The following is a description of a gene set: Any process that modulates the frequency, rate or extent of ossification, the formation of bone or of a bony substance or the conversion of fibrous tissue or of cartilage into bone or a bony substance. Human Gene Set: GOBP_REGULATION_OF_OSSIFICATION species: Homo sapiens, and this is the list of marker genes: CCR1, ACVR2B, MIR208A, SGMS2, OSR1, STATH, TMEM119, RFLNB, ANKH, GATA1, DDR2, ALOX5, SIX2, ADRB2, SOST, CCN3, BCOR, MDK, TMEM53, SMAD6, BMP7, GDF10, GREM1, ANO6 (anoctamin 6), ATRAID, PTH, WNT10B, TENT5A, BMP4, BMP3, NIPBL, OSR2, ISG15, KREMEN1, WNT5A, MAPK3, SFRP1, CCL3, DHRS3, BMP6, ZMPSTE24, VDR, MAPK14, CYP27B1, WNT4, BGLAP, GFRA4, RFLNA, SLC8A1, DKK1, P3H1, ACTN3, SOX11, INTU, LTBP3, PTN, PTPN11 (protein tyrosine phosphatase non-receptor type 11), TRPM4, TGFB1, CHSY1, RXRB, CSF1, PBX1, TWIST1, NOTUM, SOX9, RUNX2, BCL2, KL, MAPK1, PKDCC, SUV39H1, ACVR2A, NBR1, ENPP1, BMP2K, KREMEN2, SMAD7, TXLNG, SMAD3, FGF23, BMP2, SETD2, ECM1, LTF, ADGRV1, P2RX7, EGR2, ACVR1, SMAD2, ZBTB16, S1PR1, TFAP2A, FBN2, CALCR, HIF1A, COMP, LRP4, SLC20A2, NELL1, MGP, FAM20C, RXRA (retinoid X receptor alpha), OXT, BMPR2, TAC1, FZD9, GPM6B, TACR1, CCN1, PTK2B, ACVR1B, BMPR1B, BMPR1A, ADCY10, ATP2B1, PHOSPHO1, AHSG, RBPJ, MATN1, CCDC134, MEF2C, ADGRG6, SRGN, NOTCH1, TOB2, IFITM5